Given this list of marker genes CPLX2, MMP28, INHBB, LINC02593, HABP2, SEMA4G, CAPS, SERPINA6 (NCBI Gene Id 866), RTN4RL1, NTS (neurotensin), TPPP3, ITGA11, EFCAB12, DEGS2, TM4SF20, SLC52A1, ANKS4B, BCAS1, TYMSOS, C9orf152, OPRL1, CDH17, CRIP3, SPACA9, CEBPA-DT, ELN, SFRP4, H1-10-AS1, SYNGR4, KSR2, FUZ, NEB, RDM1, SLC7A7, GPR162, LINC00313, ST6GAL2, CHST13 (NCBI Gene Id 166012), E2F2, CFAP263, SERPINF2, HLA-DMB, TMEM37, CIDEC, VWA5B2, KRT4, DOK4, BAAT, ANXA9, TJP3, LLGL2, WDR97, HR, EPHB3, TONSL, MCF2L, CDCA7L, ZDHHC8BP, NEIL1, RAP1GAP, RAB40B (RAB40B, member RAS oncogene family), SLC23A1, MYO1A, IQCC, SLC29A4, RERG, IL17RB, LIAT1, LINC02870, KIF12, DACT2, PRR36, CLDN3, ADSS1, ABHD1, RIBC2, C5, CCER2, SLC3A1, FGFR4, AQP3, CKMT1B, PRODH, TEDC2, CACNG4, EPS8L3, RAB37, NT5M, CYP4F12, FGFR3 (fibroblast growth factor receptor 3), PROCA1, TERT, AMBP, KCNJ11, GALM, INSL4, CCDC74B, HOXB13, MB, ADH6, SCARA5, BCAM, FCGBP, APOH, VMO1, AKR1C2, PADI2, HNF1A-AS1, NEURL1B, USH1C, ANXA13, DIPK1B, CCDC34, LTB, MUC5B, MMP24, DDC, CLDN2, CCN5, here is a description of the gene set: Genes down-regulated in RSV (A549 cells, MOI: 2, 24hpi) from publication Blanco-Melo D, Nilsson-Payant BE, Liu WC, Uhl S, Hoagland D, Møller R, Jordan TX, Oishi K, Panis M, Sachs D, Wang TT, Schwartz RE, Lim JK, Albrecht RA, tenOever BR (PMID 32416070) Analysis of the transcriptional response to SARS-CoV-2 compared with other respiratory viruses, including MERS-CoV, SARS-CoV-1 (SARS), human parainfluenza virus 3 (HPIV3), respiratory syncytial virus (RSV), and IAV. species: Homo sapiens Human Gene Set: BLANCO_MELO_RESPIRATORY_SYNCYTIAL_VIRUS_INFECTION_A594_CELLS_DN